Given this list of marker genes UBA52, RNF103, MARCHF6, EDEM1, AMFR, EDEM3, TRIM13, RNF5, EDEM2, UGGT1, RNF185, RPS27A (NCBI Gene Id 6233), OS9, MAN1B1 (NCBI Gene Id 51697), SEL1L, DERL2, UGGT2, SYVN1, RNF139, UBB, UBC, here is a description of the gene set: studied in species Homo sapiens Proteins that are released from the CNX or CRT complex with folding defects accumulate in a compartment of the ER called ERQC. Here, the enzymes UGGG1 or UGGG2 are able to recognize glycoproteins with minor folding process and re-add the glucose on the alpha,1,3 branch; this is a signal for the transport of these glycoproteins back to the ER, where they can interact again with CNX or CRT in order to achieve a correct folding. At the same time that the glycoprotein is in the ERQC, the enzyme ER mannosidase I progressively removes the mannoses at positions 1A, 2A, B, C on N-glycans; when the mannose on 1A is trimmed, UDP-Glc:glycoprotein glucosyltransferases 1 and 2 (UGGT1 and 2) are no longer able to re-add the glucose, and therefore the protein is destined for ERAD. Glycoproteins subject to endoplasmic reticulum-associated degradation (ERAD) undergo reglucosylation, deglucosylation, and mannose trimming to yield Man6GlcNAc2 and Man5GlcNAc2. These structures lack the mannose residue that is the acceptor of glucose transferred by UGGT1 and 2. For years it has been thought that the removal of the mannose in position B of the N-glycan was the signal to direct proteins to degradation. However, this mechanism has been described better by Avezov et al and it has been demonstrated that even glycoproteins with Man8 or Man7 glycans can be re-glucosylated and interact again with CNX or CRT (for a review on this topic, see Lederkremer 2009 and Maattanen P et al, 2010). part of: Calnexin/calreticulin cycle Reactome Pathway: ER Quality Control Compartment (ERQC)